Given this list of marker genes NAGK, FCGR2A, DMXL2, CTBP2, MPP1, P2RX1, HSBP1, QPCT, PLAUR, CEBPD, HCK, IL1RN, CTSB, KCTD12, MYOF, CLPB (ClpB family mitochondrial disaggregase), IFI30, C15orf39, PILRA, CSF3R (NCBI Gene Id 1441), CD14, NCF1C, CD36, AIF1, NLRP3, PECAM1, GPX1, TBC1D8 (TBC1 domain family member 8), HLA-DMA, GLA, CORO1C, MILR1, SIRPA, PLCG2, SLC27A3, GRN, PSAP, IGSF6, SERPINA1, HNMT, TNS3, LILRB3, CYFIP1, TLR2, DUSP6, RAB31, FCGR1BP, TIMP2, STAB1, SNX10, PLXNB2, RIN2, MARCKS, VCAN, GCA, TYROBP, TNFAIP2, BCL2L2, LILRB2, HK3, GAA, IL13RA1, FCER1G, MEF2C, DAPK1, SLC2A6, CKAP4, HEXB, ADAP2, NAIP, FTL, IFNGR1, S100A12 (S100 calcium binding protein A12), GOLM1, CYRIA, SLC43A3, CLMN, MAFB, RHOQ, ATP6V0B, RNPEP, CREG1, TGFBI, NAGA, SLC7A7, NCF2, SLC36A1, HLX, ALDH3B1, SIGLEC7, CLEC4A, FGL2, CST3, MARCO, COQ2 (coenzyme Q2, polyprenyltransferase), TPD52L2, SPG21, GM2A, TST, ZDHHC7, CEBPA, CTSA, CRISPLD2, EPB41L3, NKIRAS2, PLIN3, SLC15A3, ATP6V1B2, LYN, GAB2, ITGAX, RNASE6, SLC31A2 (NCBI Gene Id 1318), IRF8, NPL, C5AR1, CAMK1, VPS37C, LGALS3, SYK, WARS1, CYP1B1, PTTG1IP, CLEC7A, CEBPB, APOBR, BLVRB, TPP1, JUP, CSF2RB, FCGR3B, DSE, LILRB1, SMCO4, CD74, KCNJ2, ACSL1, CLIC4, DUSP3, LILRA2, APLP2, RHBDF2, ALDH2, SECTM1, TP53I3, FCGRT, CYBB, RNF130 (NCBI Gene Id 55819), KYNU, ASAH1, ANPEP, FCN1, TNFSF13, PEA15, CTNNA1, PISD, BID, TOR4A, RBM47, HMOX1, SLC11A1, CFP, ADGRE2, AP1S2, CD86, TFEC, LMO2, ARHGEF40, LST1, PRKCD, TMEM164, S100A9, RASSF4, OGFRL1, APOBEC3A, MARCHF1, FPR1 (NCBI Gene Id 2357), RAB32, CCR1, CHST15, CSF1R, CTSD, RXRA, BTK, BCKDK, CD93, GAS7, HSPA6, DENND1A, CFD, ERP44, EIF4EBP1, KIAA0930, SDCBP, CSTA, GRK3, TBXAS1, BASP1, KLF4, LAT2, here is a description of the gene set: Genes down-regulated in comparison of systemic lupus erythematosus CD4 T cells versus systemic lupus erythematosus myeloid cells. from publication Hutcheson J, Scatizzi JC, Siddiqui AM, Haines GK 3rd, Wu T, Li QZ, Davis LS, Mohan C, Perlman H (PMID 18275831) Human Gene Set: GSE10325_LUPUS_CD4_TCELL_VS_LUPUS_MYELOID_DN species: Homo sapiens Gene expression profile studies have identified an interferon signature in whole blood or mononuclear cell samples from patients with systemic lupus erythematosus. This study was designed to determine whether specific lymphocyte and myeloid subsets freshly isolated from the blood of systemic lupus erythematosus patients demonstrated unique gene expression profiles compared to subsets isolated from healthy controls.